The following is a description of a gene set: Human Gene Set: MODULE_287 studied in species Homo sapiens Genes in the cancer module 287., and this is the list of marker genes: CXCL8, EFEMP1, CRYZ, GNAT2, TYR, PRB4, PHYH, CRYGD, OPA1, EDNRB, COL11A1, AOC2, GUCY2F, PRPH2, OAT, GUCY2D, HTR2B, PROM1, ABCC6, PDE6A, CRYGA, LUM, OXTR (NCBI Gene Id 5021), RS1, CDH3, CRYM, CRYAB, TACR1, MERTK, GRM8, P2RY2 (purinergic receptor P2Y2), PDE6B, CRYAA, CXCR2, RGS16, CRB1, FBN1, SORD, CYP1B1, CNGA3, MYOC, CNGA1, COL18A1, USH2A, SIX6, EML1, PDE6H, OPN1SW, KRT12, PAX2